The following is a description of a gene set: Premature atrial contractions A type of cardiac arrhythmia with premature atrial contractions or beats caused by signals originating from ectopic atrial sites. Human Gene Set: HP_PREMATURE_ATRIAL_CONTRACTIONS studied in species Homo sapiens, and this is the list of marker genes: KCNA5, CITED2, NRAS, SCN5A, TTN, GJA5, NAA10, KCNE2